Given this list of marker genes SMIM7, HAUS3 (NCBI Gene Id 79441), NPRL2, TFIP11, ISY1, THAP4, VDAC2, TMEM203, CDH10, VPS18, TRIT1, RAB40C, MAPK8IP1, MTG2, CRY2, PRX, MOGS, IL21R, RFLNB, SLC35B4, BET1L, CIAO1, EMD, HIKESHI, TMEM223 (NCBI Gene Id 79064), RPRD2, ZMYM1, CNPPD1, PPM1G, ACADM, CYP2A6, EIF2B2, BUD31, SLC30A5, INSL5, DPH5, C19orf53, PURB, SOX4, COMMD9, PSMC4, CTDSP2, TMEM37, SAP18, ING1, GABRR1, ASGR2, TNIP1, FBXO32, UQCRFS1, ATG101 (autophagy related 101), TNNT2, SAC3D1, MEN1, CD2BP2, HARS2, TOR2A, CHPF, MAGEE1 (MAGE family member E1, NCBI Gene Id 57692), GOT2, EIF1B, TIMM8B, RANBP3, FZR1, CELA2A, ABCF1, SNX17, SPHK2, TIMM29, FAM167B, HRAS (NCBI Gene Id 338029), DAZAP2, SMARCAL1 (NCBI Gene Id 50485), FRAT2, STX1A, CDPF1, ZNF688, ABL1, LRRC59 (leucine rich repeat containing 59), TAF5L, PLA2G2A, CYB561D2, PIAS4, WDR45, NAA38, DPF3, RP9, ZNF574, YPEL3, SMPD5 (sphingomyelin phosphodiesterase 5 (pseudogene)), SRPRA, SPOCK2, ADRM1, UQCRC2, SELENOK, UCK2, DAG1 (dystroglycan 1), B3GALT4, GSTZ1, IL16, PRPF3, TENM4, PTBP1, LFNG, TRAPPC4, CD27, TMEM115 (NCBI Gene Id 11070), MEPCE, PLEKHB2, C15orf39, EPYC, BEX3, TOR4A, MXD4, XRCC2, MAP3K14, HMGB2, MED22, CDCA4, RAMP3, BGN, BHLHA15, ZNF707, TUBB2A, SMAD7, PIGO, UBALD1, CCR7, FLCN, GJB5, CDC42SE1, IMP3, ALKBH4, TARBP2, MYB, RMND5B, SLC1A1, PTX3, AXIN1, SLC25A3, NOPCHAP1, NOLC1, KLF3, TBC1D10B, RAB11B, FNDC10, ZRSR2, PTGR3 (prostaglandin reductase 3), PIP5K1C, LCE1A, A4GALT, C1orf35, TMEM60, AXIN2, ISCU, CHRNA4, C1orf43, NMNAT1 (NCBI Gene Id 64802), ALDH8A1, IER5L, SEC24C, PJA1, RGS2, PSMB5, OGFOD2, MAEA, BNIP3L, THOC3, NAB2, BAP1, TMEM38A, RPP25L, ZFP36L2, GTPBP1, POLG2, VCF1, CDK5RAP1 (NCBI Gene Id 51654), SUPT4H1, NKX2-3, SIGMAR1, TMEM208, GDE1, PYCR2, TMEM186, PIP4K2C, ASB6, H1-2, VCP, SPSB3, SLC3A2, CIDEA, IGFBPL1, TPRG1L, HDAC5, ANAPC7, GTF3A, YAP1, VPS37B, AMPH, here is a description of the gene set: species: Homo sapiens Genes up-regulated in lymphoid primed multipotent progenitors: wildtype versus LYL1 knockout. Human Gene Set: GSE38681_WT_VS_LYL1_KO_LYMPHOID_PRIMED_MULTIPOTENT_PROGENITOR_UP We compared gene expression differences in Lyl-1 knockout vs wildtype LMPPs KO allele described in Pub Med ID: 21387538 from publication Zohren F, Souroullas GP, Luo M, Gerdemann U, Imperato MR, Wilson NK, Göttgens B, Lukov GL, Goodell MA (PMID 22772404)